Given this list of marker genes SMARCD2, AKT2, EDNRB, KARS1, TBX3, ATP6AP2, ITGA2, BCL2A1 (NCBI Gene Id 597), TERT, CSF1, IARS1 (isoleucyl-tRNA synthetase 1), TCF7L2, ATP6V1B2, CDH1, CDKN1A, DPF2, TNRC6B, MARK3, ATP6V1D, RARS1, BIRC7, TYRP1, SMARCC2, YWHAZ, MYRIP, RAB27A, PXDN, YWHAG, UBE2I, EEF1E1, CCND1, AKT3, CREBBP, DPF3, DIAPH1, CDKN2A, YWHAH, GXYLT2, ATP6V1F, SMARCA2, TNRC6C, SMARCE1, CREB1, BCL7B, ATP6V0A1, CDH2 (cadherin 2), ATP6V0D1, QARS1, SIN3A, SMARCD1, ARID1B, AGO4, CDC25B, LEF1, SMARCB1, KITLG, MLANA, ATP6V1G1, PPARGC1A, SS18L1, LARS1, ZIC1, WNT3A, SNAI2, ATP6V1C1, SOX9, TCF7, AGO1, ARID1A, ATP6V0C, GPR143, MC4R, MOV10, ATP6V1A, YWHAB (tyrosine 3-monooxygenase/tryptophan 5-monooxygenase activation protein beta), IRF4, TNRC6A, SUMO1, DARS1, HINT1, EP300, ATP6V0E2, XPO1, PXN, MC5R, ATP6V1H, MC1R, PMEL, YWHAE, DPF1, SIRT1, BCL2, CTNNB1, EDN3, SS18, TCF7L1, EDN1 (endothelin 1), AIMP1, EDIL3, USP46, RPS6KA1, BCL7C, SMARCA4, KIT (KIT proto-oncogene, receptor tyrosine kinase), AGO3, POMC, SOX10, ID1 (inhibitor of DNA binding 1), ATP6V1E1, TFAP2A, PLK1, MAPK1, CCNB1, SYTL2, CEACAM1, LIG1, SERPINE1, USF1, MYO5A, MCM5, MARS1, MITF, AIMP2 (NCBI Gene Id 7965), HDAC1, MAPK14, MIR211, ZEB1, MET, SMARCC1 (SWI/SNF related, matrix associated, actin dependent regulator of chromatin subfamily c member 1), ATP6V0E1, ATP6V0B, ACTL6A, TNFSF11, TYR, ACTB, POU3F2, TFE3, SMARCD3, FOXD3, STT3B, GMPR, DCT, PAX3, BCL7A, GSK3B, MLPH, ALX3, EPRS1, TBX2, SOX2, TFEB, MAPK3, CDK2, MCM2, AGO2, TRPM1, TFEC, ASAH1, BRCA1 (NCBI Gene Id 672), MC3R, DICER1, here is a description of the gene set: Human Gene Set: REACTOME_MITF_M_REGULATED_MELANOCYTE_DEVELOPMENT studied in species Homo sapiens MITF-M-regulated melanocyte development